Given this list of marker genes LPAR6, ASS1, GAS2L1, CD34, ITGA6, PALM, GIMAP6, H1-0, PCDHGC3, REEP5, MYO5C, APP, DAPK1, IFITM1, GIMAP5, DUSP7, SNRPN, MDFIC, SPARC, EGFL7, DPYSL2, SERPINB9, SLC38A1, KYNU, DNM1, KLF9, DAB2, FYN, ST3GAL5 (NCBI Gene Id 8869), VEGFA, CISH, CD200, ALDH2, LHFPL2, KCNN4, CIITA, EVL, CLIC4, here is a description of the gene set: BACKGROUND: In patients with acute myeloid leukemia (AML) a combination of methods must be used to classify the disease, make therapeutic decisions, and determine the prognosis. However, this combined approach provides correct therapeutic and prognostic information in only 50 percent of cases. METHODS: We determined the gene-expression profiles in samples of peripheral blood or bone marrow from 285 patients with AML using Affymetrix U133A GeneChips containing approximately 13,000 unique genes or expression-signature tags. Data analyses were carried out with Omniviz, significance analysis of microarrays, and prediction analysis of microarrays software. Statistical analyses were performed to determine the prognostic significance of cases of AML with specific molecular signatures. RESULTS: Unsupervised cluster analyses identified 16 groups of patients with AML on the basis of molecular signatures. We identified the genes that defined these clusters and determined the minimal numbers of genes needed to identify prognostically important clusters with a high degree of accuracy. The clustering was driven by the presence of chromosomal lesions (e.g., t(8;21), t(15;17), and inv(16)), particular genetic mutations (CEBPA), and abnormal oncogene expression (EVI1). We identified several novel clusters, some consisting of specimens with normal karyotypes. A unique cluster with a distinctive gene-expression signature included cases of AML with a poor treatment outcome. CONCLUSIONS: Gene-expression profiling allows a comprehensive classification of AML that includes previously identified genetically defined subgroups and a novel cluster with an adverse prognosis. Top genes from cluster 11 of acute myeloid leukemia (AML) expression profile; 67% of the samples are FAB M4 or M5. from publication Valk PJ, Verhaak RG, Beijen MA, Erpelinck CA, Barjesteh van Waalwijk van Doorn-Khosrovani S, Boer JM, Beverloo HB, Moorhouse MJ, van der Spek PJ, Löwenberg B, Delwel R (PMID 15084694) Human Gene Set: VALK_AML_CLUSTER_11 species: Homo sapiens